Given this list of marker genes FAM168A, NCOA2, NR4A3, FRY, RFX1, IL6ST, KLRC1, KLHDC10, STRN3, SLTM, PNPT1, KCNA1, RIC1, BCAT2, SLC12A5, NFIX, PNISR, NEUROD1, CHD9, UGP2, MKRN3, DOCK5, YIPF4, DYNLT5 (NCBI Gene Id 200132), CHKA, GATA6, DCAF4L2, PIAS4, SEMA5A, FAM222A, TEF, ZNF85, NR2F2, MYCBP2 (MYC binding protein 2), CES5A, RABGAP1L, SCUBE3, RRM2B, PPHLN1, SGMS1, MYH9, ARMC1, SRSF8, HIPK1, DNAAF9 (NCBI Gene Id 348549), NHLRC3, NPTN, MOB3A (NCBI Gene Id 126308), BCL11A, LGI2, KCNB2, LRRC8C, DYNC1LI2, BAHCC1, UNKL, PDE10A (NCBI Gene Id 90632), DBT, CPEB2, AFF1, ZFHX3, PRPF40A, FHL2, TEAD1, FCHO2, DPF2, SNIP1, ZNF431, ADCY3, MTDH, TMEM255A, HERPUD2, FNIP1, PITPNA, FAM133B, HELQ (NCBI Gene Id 113510), SVIP, ARID4B, CACNB4, MAN2A1, EMILIN2, RIOX2, DSTYK, AP1AR, SGK3, GDF6, HCN2, C8orf44-SGK3, TWF1, ZIC1, FBN1, ZNF41, PLXDC2, KALRN, KDELR2 (NCBI Gene Id 11014), BSN, ROBO2, RORA, SCAF11, SYT14, RAB9B, NKX2-4, RTN1, ADM, HAS3, SRPRA, TRAK2, SYNDIG1, PTAR1, MAPRE1, RGS3, SH3PXD2A, NEFH, SLC17A6, NPHP3, PPP1R37, FNBP4, MBLAC2 (metallo-beta-lactamase domain containing 2), PDE6C, KMO, SETD5, TRAF3, ACOX1, HNF1B, NCOA6, GUCY1A2, MYO1B, ROBO1 (roundabout guidance receptor 1), RNF38, IQGAP2, PCDH20, MARCHF4, STYXL1, NPTX2, DYRK2, ZFYVE21, KLRF1, BMAL1, KLHL14, SUFU, CALCRL, PTPRO, SFXN1, TCP11, GAA, MINAR1, ZNF430, CD2AP, BAZ2B, ASH1L, TCF21, KLRC2, CLOCK, ARRDC3, BNIP2, ZNF512B, KBTBD8, AMMECR1L, ZBTB5, EIF5, SPRED1, ZNF100, PPFIA2, PCOLCE2, KHDRBS3, ADAMTSL1, TECPR2, RAB12, IKZF2, ZCCHC2, KIF5B, RGS9, ITGAV, CDCA7L, YWHAZ, LRRC1, SREK1, DDX3X, NUDT16, SCYL2, JMJD1C, ACTB, BHLHE41, FBXW7, FZD7, DYRK1A, FMN2, ZNF804A, GRHL1, PCMTD1, ATG3, CNIH1, NFIA, SLC5A7, ARFGEF2, ADAM23, CCNC, SORBS2, PITPNM2, GLCCI1, GNPDA1, SYPL1, THSD7B, MMD, DPP10, TP63, ZSWIM7, OSBPL6, ITGA5, PDCD6IP, SYNPO2, PATJ, CCDC93, ESRP1, RBM47, FMN1, PIK3CA, EGR2, STRC, SLC38A2, ATL3, SNAP47, OTUD7B, TMPRSS11B, DLC1, NOX4, FAM20C, NCAPD3, RPL15, RBMS3, SEPTIN8, SH3D19, TMCC3, MYRIP, NSMF, INSIG1, JOSD1, PALLD, ZNF721, FAM120A, LSM11, NEXMIF, HIVEP3, GTF2E2, SELENOT, DCAF6, RNF4, TNPO1, PDS5A, DDX3Y, PLXNA4, ACADL, ANTXR2, UNC5A, PHF6, COX11 (NCBI Gene Id 1354), VASH2, MTF2, MAP2K4, SNAPC1, ZNF773, ZNF703, IDH1, SGPP1, PDZD2, SNAI2, REST, here is a description of the gene set: from publication Chen Y, Wang X (PMID 31504780) Human Gene Set: MIR4325 studied in species Homo sapiens Genes predicted to be targets of miRBase v22 microRNA hsa-miR-4325 in miRDB v6.0 with MirTarget v4 prediction scores > 80 (high confidence targets).